Given this list of marker genes PTGER2, PTGDR, HPGD, PTGER4, PTGER3, PTGDR2, PTGER1, PPARG, PTGFR, PTGIR, TBXA2R, here is a description of the gene set: species: Homo sapiens Combining with a prostanoid, any compound based on or derived from the prostanoate structure, to initiate a change in cell activity. Human Gene Set: GOMF_PROSTANOID_RECEPTOR_ACTIVITY